Given this list of marker genes HADHA, ECHS1, ACSL6, ACAT1, ACADM, SLC25A20, DECR1, LPL, CPT2, TPI1, LIPF, ACSL3, GCDH, LIPC, ACSL4, HADHB (hydroxyacyl-CoA dehydrogenase trifunctional multienzyme complex subunit beta), CPT1A, ACADL, ACSS2, CRAT, GK, LIPE, GK2, ACSL5, ACSL1, HADH, ECI1, CPT1B, DLD, GPD2, PNPLA2, ACADVL, ACADS, CHKB (choline kinase beta), here is a description of the gene set: species: Homo sapiens Fatty acid beta-oxidation Human Gene Set: WP_FATTY_ACID_BETAOXIDATION